The following is a description of a gene set: The process of assisting in the covalent and noncovalent assembly of single chain polypeptides or multisubunit complexes into the correct tertiary structure. studied in species Mus musculus Mouse Gene Set: GOBP_PROTEIN_FOLDING, and this is the list of marker genes: Tbcb, Cct8, Tbca, Hspa1a, Hspd1, Fkbp11, Dnajb1, Pfdn2, Ppie, P4hb (prolyl 4-hydroxylase, beta polypeptide), Pdcl, Sh3glb1 (SH3-domain GRB2-like B1 (endophilin)), St13, Ptges3l, Grpel2, Hspa2, Hspa4, Nudc, Clu, Dnajc3, Ppih, Mesd, Ppia, Ppil1, Cct8l1, Ppib, Grpel1, Cd74, Cdc123, Pofut2, Pfdn4, Umod, Dnaja2, H2-DMa, Dnajb13, Dnajb4, Ppid, Cct7, B2m, Hspb6, Ahsp, Hspa14, Arl2, Clpx, Unc45a, Ero1a, Nppc, Tor2a, Fkbp6, Dnajc2, Agr2, Nudcd2, Rp2, Grn, Sgta, Tor1b, Tbcc, Pdcl2, Dnajc1 (DnaJ heat shock protein family (Hsp40) member C1), Hsp90aa1, Pdcd5-ps (NCBI Gene Id 100046198), Cwc27, Erp27, Cct6a, Zmynd10, H2-DMb2, Fkbp2, Tor1a, Nppa, Dnajb7 (DnaJ heat shock protein family (Hsp40) member B7), Cct6b, Bag5, Hspb2, Selenof, Pfdn1, Tbcd, Qsox2, Pfdn5, Dnaja1, Nudcd3, Chchd4, Ttc4, Pdia3, Hspb1, Stub1, Entpd5, Trap1, Bag1, Telo2, Sdf2l1, Hspa5 (NCBI Gene Id 99198), P3h1, Hspe1-rs1, Dffa, Hsp90ab1, Cct5, Ppig, Hspa9, Ric8b, Calr4, Fkbp4, Hsp90b1, Wdr83os, Dnajb14, Hyou1, Unc45b, Pex19, Ppwd1, Ptges3, Fkbp8, Cct2, Pdcl3 (NCBI Gene Id 96896), Tcp1, Crtap, Dnajc10, Ahsa2, Hspa4l, Ero1b, H2-DMb1, Ptges3-ps, Ube4b, Cryab, Pdrg1 (NCBI Gene Id 99251), Hspa1l, Fkbp9, Cryaa, Chordc1, Pdcd5, Dnlz, Dnaja4, Cct4, Cdc37, Pdilt (protein disulfide isomerase-like, testis expressed), Erp44, Hsph1, Ppif, Fkbp5, Zpr1, Ccdc47, Dnaja3 (DnaJ heat shock protein family (Hsp40) member A3), Mkks, Calr, Vbp1, Dnajb12, Canx, Clgn, Gfer, Tbce, Ranbp2, Ppic, Ppil2, Dnajc25, Calr3, Dnajb2, Ahsa1, Hspa13, Dnajb11, Pfdn6, Dnajc5 (NCBI Gene Id 99185), Dnajb3, Hspa8, Cdc37l1, Dnajc7, Pdia4, Nppb, Txndc5, Hspe1, Ric3, Tsc1, Dnajb8 (DnaJ heat shock protein family (Hsp40) member B8), Pdia5, Sdf2, Tbcel, Dnajb6, Pdia2, Ppil3, Cct3, Dnajc18, Dnajb5, Hspa1b, Qsox1, Fkbp10, Ric8a, Nktr, Elp6